Given this list of marker genes SRCAP, PRDM16, MMP23B, LUZP1, NALCN, HDAC6, HES7, B4GAT1, TBC1D24, WNK3, GPX4, NFASC, SCUBE3, PTPN11, CEP152, TOR1A, KCNAB2, CASZ1, CCDC22, ATP6V1B2, CENPJ, NUP88, DNMT3A, HSPG2, TBX5, SOX2, FLNB, CHST3, VANGL1, B3GALT6, PAICS, B3GAT3, RRAS2, WASHC5, ROR2, RSPO2, TBX6, SIX6, RERE, SPEN, BMP2, FBN1, VPS35L, PRKCZ, ATR, SKI, FLI1, DPYSL5, LBR, HNRNPR, KYNU, MYF5, WNT3, SNRPB, BMPER, FUZ, TBX4, RNU4ATAC, ALDH1A2, PRIM1, DONSON, SOX9, UBE4B, RPS19, TBCK, GABRD, CPLANE1, IFT43, PDPN, here is a description of the gene set: Human Gene Set: HP_MISSING_RIBS Missing ribs species: Homo sapiens A developmental anomaly with absence of one or more ribs.